The following is a description of a gene set: Genes predicted to be targets of miRBase v22 microRNA hsa-miR-5004-3p in miRDB v6.0 with MirTarget v4 prediction scores > 80 (high confidence targets). studied in species Homo sapiens from publication Chen Y, Wang X (PMID 31504780) Human Gene Set: MIR5004_3P, and this is the list of marker genes: UBE4B, EHHADH, FKBP5, ELK3, GPR183, PCDH7, NEO1, GNAI3, KCNJ6, FXR2, UGT2B17, ABCC4, CBFA2T3, CNOT7, IQSEC3, SYT4, SPA17, GORAB, COL8A1, KLF9 (KLF transcription factor 9), AFF4, ACSL4, MARVELD3, GALK2, ZNF197, ASH1L, THRSP, PCSK5, WAPL, ZNF208, NHLH2, FGF13, VAMP7, LIX1, KIF13B, SPARCL1, OSBPL6, EN2, ACADSB, SREK1, TTF2, DNM1L, SESN3, TTC29, RNF138, SLC4A7, SHOC1, PHACTR2, ZNF22, CBLL1, ABL1, DPY19L1, TBL2, TES, PBRM1, CROT, CBL (NCBI Gene Id 867), MRPL43 (mitochondrial ribosomal protein L43), RBAK, SLC18A2, PIGM, PER3, ZNF714, ALDH6A1, ENSA, SH2D4B, CHL1, CCDC141, VIRMA, CAPZA1, ZBTB34, HAPLN1, CHD1, ITGA4, APOBEC4, ONECUT2, SORCS1, ZCCHC14, POU2F1, FSCN3, LMLN, SEC22C, DAP, EIF5, BNC2, KCND2, PGM2L1, ZFHX2, KRBOX5, METTL8, KCNT2, PHOX2A, PLEKHA1, IGFBP7, GSDME, ZNHIT3, GPR171, FAM131B, SLC27A2, ELOVL5, CCDC177 (NCBI Gene Id 56936), DOK6, DUSP6, ANKRD13C, BBX, RBMS3, IPO7, SKIC3, C11orf97, RPS6KA2, PPP1CB, TMEM170B, ETV3, AP3B1, CEP43 (NCBI Gene Id 11116), CASP1, HOMER2, ARID2, ADH1A (NCBI Gene Id 124), GSK3B, SPON1, NRAS, ERC2, ADH1C, ACTR3, C14orf28, PPP2R5E, SLFN5, KIF26B, RPL34, SRGAP2, CLEC3A, LRIF1, MTMR4, PRMT9